The following is a description of a gene set: HuR (ELAVL1) binds and stabilizes mRNA species: Homo sapiens Human Gene Set: REACTOME_HUR_ELAVL1_BINDS_AND_STABILIZES_MRNA, and this is the list of marker genes: PRKCA, TNFSF13, SET, NUP214, PRKCD, ANP32A, XPO1, ELAVL1 (ELAV like RNA binding protein 1)